The following is a description of a gene set: Mouse Gene Set: REACTOME_TRANSPORT_OF_GAMMA_CARBOXYLATED_PROTEIN_PRECURSORS_FROM_THE_ENDOPLASMIC_RETICULUM_TO_THE_GOLGI_APPARATUS Transport of gamma-carboxylated protein precursors from the endoplasmic reticulum to the Golgi apparatus studied in species Mus musculus, and this is the list of marker genes: F7, Proz, F10 (NCBI Gene Id 14058), F9, Pros1, Proc, F2, Gas6, Bglap2